Given this list of marker genes Clec2d, Ppa1, Sh3gl1, Tgtp1, Ddx24, Stat1 (signal transducer and activator of transcription 1), Nmi, Tbk1, Ctss, Trim30a, Gbp7, Hspa5, Psma4, Trim34a, Msn, Xrn2, Ifi35, Gbp9, Itm2b, Ms4a6b, Helz2, Ifitm3, Atp8b4, Tnfsf8, Ilrun, Psma2, Dpp4, Ly6e, Gramd2b, Art2b, Pgd, Il2rg, Tapbp, Armc3, Ccnd2 (NCBI Gene Id 97325), Prrc2c, Ifit3b, Calhm6, H2-D1, BC051226, Cycs, Ifit2, Oasl2, Xrn1, Xaf1, Psme2, Sppl2a, Adar, Lgals3bp (lectin, galactoside-binding, soluble, 3 binding protein), Mgat1, Zup1, Znfx1, Usp18, Ankfy1, Psma5, Parp11, Ttc39b, Sdc3 (syndecan 3), Map2k1, Aida, Tapbpl, Phf11a, Oasl1, Isg20, Rnf213, Hsh2d, Svbp, Slco3a1, Cmpk2, Irf7, Ly6a, Naa20, Sp100, Nup210, Sp140, Ifit1, Mycbp2, Ifi27l2a, B2m, Rnf114, Oas1a, Card11, Oas2, Ifit3, Stat3, Rigi, Trim12a (tripartite motif-containing 12A), Isoc1, Vars1, Bbx, Plaat3, H2-T22, Mitd1, Ppp6r1 (NCBI Gene Id 76753), Ezr, Chmp4b, Parp10, Asb13, Mndal, Ndrg3 (NCBI Gene Id 99063), Tap1, Trim21, Akr1b1, Zc3hav1, Clic4, Zcchc2, Tmem192, N4bp1, Arf4, Hk1, Ifi214, Psme2b, Tcof1, Bst2, Ifi208, Gbp5, Daxx, Tasor2, Rbck1, Phyh, H2-Q4 (histocompatibility 2, Q region locus 4), Gbp4, Stat2, Arl6ip1, Cmc1, Iigp1, Lgals9, Nes, Smchd1, Fam111a, Laptm4a, Ifi203, H2-T24, Isg15, Samhd1, Irf1, Mrpl30 (NCBI Gene Id 69516), Azi2, Cd86, Tor1aip2, Ube2l6, Samd9l, Rbm43, Ifi44, Eif2ak2, Parp14, Ncoa7, Casp8, Irgm2, Trim25, Ltb, Trim56, Psme1, Pcgf5, Keap1, Irf2, Trim14, Treml2, Phgdh, Morc3, Pnpt1, Trim26, Nub1, Man2a1, Rtp4, Cd164 (CD164 antigen), Tut4, Gbp2, Igtp, Tmem184b, Capza2, Gbp6, Parp9, Apobec3, Eeig1, Trim30c, Socs3, Tbrg1, Shisa5, Phf11b, Vps54, Selenow, 9930111J21Rik2, B4galt5, Ifi204, Ubald2, Notch1, Cxcl10, Pml, Cd47, Gzma, Trafd1, Atm, Tnfsf10, Herc3, Cd69, Tor3a, Gpr18, Gbp8, Phc2, Nampt, Tmbim6, Plgrkt, Nlrc5, Dhx58 (NCBI Gene Id 93832), Ogfr, Fnbp4, Tcstv4, Slfn2, Max, Eif2s2, Mx1, Etnk1, Mov10, H2-K1, Cnp, Epsti1, Rabepk, Zbp1, Gbp3, Phf11c, Igfbp4, Cd274, Idnk, Lgals8, Trim12c, Rnf19b, Tgtp2, Cd53, Sidt1, Taldo1, Inpp1, Rbl1, Phip, Vcpip1, Tbc1d1, H2-Q7, Slfn1, Ddx60, Ifih1, Tor1aip1, Ms4a4c (NCBI Gene Id 76011), Fchsd2, Dbnl, Nsd3, Sh3glb1, Slc25a22, Itpr1, Psmb9, Atg13, Insl6, Ifi213, Parp12, Uba7, Pdia3, Acadl, Cnot6l, Gtpbp2, Grina, Gpr65, Irgm1, Ly6c1, Sell, Mthfd2, Socs1, Jaml, Tpst2, Nsg2, Slfn8, Ascc3, Herc6, Irf9, Slfn5, Tap2, Sp110, Evl, Psma7, Rsad2, Pttg1, Psmb8, Aldoa, Dtx3l, Ifi47, Trim30d, Psmb10, Ifi209, Oas3, Ms4a4b, Gadd45g, Cd2, Tspo, H2-M3, Usp25, Ifi206 (NCBI Gene Id 240921), H2-T23, Ifit1bl1, Nt5c3 (NCBI Gene Id 76506), here is a description of the gene set: Cytokines mediate cell-cell communication in the immune system and represent important therapeutic targets. A myriad of studies have highlighted their central role in immune function, yet we lack a global view of the cellular responses of each immune cell type to each cytokine. To address this gap, the authors created the Immune Dictionary, a compendium of single-cell transcriptomic profiles of more than 17 immune cell types in response to each of 86 cytokines (>1,400 cytokine-cell type combinations) in mouse lymph nodes in vivo. A cytokine-centric view of the dictionary revealed that most cytokines induce highly cell-type-specific responses. For example, the inflammatory cytokine interleukin-1β induces distinct gene programmes in almost every cell type. A cell-type-centric view of the dictionary identified more than 66 cytokine-driven cellular polarization states across immune cell types, including previously uncharacterized states such as an interleukin-18-induced polyfunctional natural killer cell state. Genes positively differentially expressed in cell type: CD4+ T cell upon treatment with cytokine: IFN-β in mouse lymph nodes in vivo. species: Mus musculus Mouse Gene Set: CUI_T_CELL_CD4_IFNB_RESPONSE_UP from publication Cui A, Huang T, Li S, Ma A, Pérez JL, Sander C, Keskin DB, Wu CJ, Fraenkel E, Hacohen N (PMID 38057668)